The following is a description of a gene set: Binding to a gamma-aminobutyric acid (GABA, 4-aminobutyrate) receptor. studied in species Homo sapiens Human Gene Set: GOMF_GABA_RECEPTOR_BINDING, and this is the list of marker genes: SHISA7, PPP2CA, MAF1, GABARAPL1, GABRG1, LHFPL4 (NCBI Gene Id 375323), GABARAPL2, GABARAPL3, JAKMIP1, PLCL2, TRAK2, ERBB4, GABRB1, TRAK1, AKAP5, ARFGEF2, GABARAP (GABA type A receptor-associated protein), CLPTM1, GABRA5